Given this list of marker genes NF1, PTEN, SDHA, MAX, CCND1, PIK3CA, SPRED1, SDHB, SDHC, GNA11, NF2 (NCBI Gene Id 654093), RB1, FH, XPC, KRT1, CYSLTR2, CHEK2, MDH2, BRAF, VHL, STK11, XPA, ERCC2, USF3, SDHD, DLST, KLLN, BAP1, IFNG, ERCC4, NDP, SDHAF2, ERCC3, TSC2 (NCBI Gene Id 7249), KRT10, ERCC5, GNAQ, TMEM127, SEC23B, DDB2, TSC1, SF3B1, SLC25A11, TP53, KIF1B, MBD4, AKT1, RET, MSH6, here is a description of the gene set: species: Homo sapiens Neoplasm of the eye A tumor (abnormal growth of tissue) of the eye. Human Gene Set: HP_NEOPLASM_OF_THE_EYE